The following is a description of a gene set: Mouse Gene Set: GOBP_POSITIVE_REGULATION_OF_PROTEIN_SERINE_THREONINE_KINASE_ACTIVITY Any process that increases the rate, frequency, or extent of protein serine/threonine kinase activity. studied in species Mus musculus, and this is the list of marker genes: Fgf2, Tlr4, Tnfrsf11a, Drd4, Pdcd10, Bcl10, Spatc1l, Nrxn1, Snca, Edn3, Mst1r, Irgm2, Map2k7, Pih1d1, Mapk8ip3, Map3k10, Sirt1, Ccr7, Cd40, Ptprc, Prox1, Cripto, Ralb, Cab39, Syap1, Pim1, Ntrk3, Ajuba, Ern1, Ltf (NCBI Gene Id 94320), Agt, Ager, Arhgef5, Dvl2, Psen1, Tab1, Ccny, Adrb2, Cemip, Rgcc, P2rx7, Map3k7, Syk, Map3k4, Thbs1, Fgd4, Edn1, Axin1, Map3k11, Fzd4, Akt1, Ifng, Pdgfa, Pdgfrb, Pik3r6, Insr (insulin receptor), Nek10, D1Pas1, Map3k5 (NCBI Gene Id 320994), Adipoq, Nox4, Gab1, C1qtnf9, Slc8a2, Src, Map3k13, Higd1a, Zeb2, Tnf, Cd24a, Adam9, Maged1, Fgf1, Adra2a, Tpd52l1, Hras (Harvey rat sarcoma virus oncogene), Cib1, Wnt5a (NCBI Gene Id 77565, wingless-type MMTV integration site family, member 5A), Epha4, Fgd2, Adam17, Spdya, Ptpn1, Htr2b, Lrrk2, Spdye4a, Psrc1, Rapgef2, Ccnd2, Rasgrp1, Il1b, Taok3, Ccl19, Irgm1, Fgf18, Kit, Ern2, Gpr39, Mapre3 (NCBI Gene Id 100732), Pdgfb, Ccnd1, Psmd10, Tead1, Pak1, Tlr6, Map2k1, Pde5a, Sash1, Erbb2, Map2k6, Ntf3, Flt1, Il34 (NCBI Gene Id 76527), Ccnd3, Ip6k2, Ddx3x, Irak1, Map3k1 (mitogen-activated protein kinase kinase kinase 1), Dab2ip, Fgfr1, Pik3cg, Tnfsf11, Rhoa, Map2k4, Fzd5, Stil, Traf2 (TNF receptor-associated factor 2), Erp29, Etaa1, Camk1, Map2k2, Traf6, Tirap, Dusp19, Vangl2, Hmga2, Pik3r5, Fcer1a, Map3k12, Ceacam1, Map4k2, Robo1, Kitl (NCBI Gene Id 17311), Ezh2 (NCBI Gene Id 14056), Igtp, Tenm1, Ppp2ca, Egfr, Magi3, Rps3, Tcim, Fzd8